Given this list of marker genes TFAP2B, GTSF1, IZUMO1, MAPK10, MST1R, PTCRA, OPN1SW, TRIM33, KCND2, KCNIP4, ZNF358, SLN, HVCN1, LEFTY2, KLHL23, DYRK1B, PLAG1, TWSG1, KCNJ2, RIN1, KRT76, FGF16, ARHGAP44, KISS1R, HOXC13, MIR124-1HG, TMEM269, WT1, KAZN, CRYBA2 (NCBI Gene Id 1412), ATP1A4, MARVELD2, SLC6A18, AMHR2, APLNR, MIOX, TACR3, BCLAF3, SOST, MYOD1, KRTAP3-3, DLK1, ZNF25, ENTPD8, NHLRC1, KCNJ14, ERBB2, TMTC4 (transmembrane O-mannosyltransferase targeting cadherins 4), TENT5B, IZUMO1R, MAL, TSPAN9, COL8A2, LCK, C1QL3, FSHB, LCN2, P2RY6, LRRC31, PINK1, MYRIP, LGI4, ENOX1, SLC22A12, TEC (tec protein tyrosine kinase), GJC3, NNMT, KLHL1, TTR, RAB42, IFITM5, EFCAB3, OCIAD2, GATA2, INHBB, GRIA4, IL10, CCDC169, FABP3, GPR27, CPN2, GCOM1, GPR20, COL24A1, SORBS3, OSR2, RAMP2, CORO6, JAG2, DLC1, CD209, DHX29, HCRTR2, SLC5A10, VTI1A, DPPA5, HNF1A, TSKU, PRSS54, PAK6, TRAM1L1, ARHGEF9, WDR45B (WD repeat domain 45B), PDE6B, SEMA5B, SH3D19, ALDH1A3, DUSP8, DISP3, KIF14, TPBG, GJD4, PLAC9, FAM221A, MAP7, GPAT3, CYYR1, CDKN1A (NCBI Gene Id 1026), SH2D2A, STXBP6, CCDC24, ITSN2, GPR135, ACTRT3 (actin related protein T3), FUNDC2, FAM110A, CA12, FAM163B, FOXS1, ATP6V0D2, KRT31, ATP11C, ZNF236, MSH3, OTOA, SLC12A5, CA9 (NCBI Gene Id 768), KRT6A, LRFN3, PPP1R1B, GPR26, VSX2 (visual system homeobox 2), NKAIN1, DHX16, SCRN2, HDHD2, CUX2, CASQ1, PSAPL1, FABP12, ANP32A, B3GALNT1, METTL27, GUCY1A1, CFAP69, ADRA2A, ZCCHC14, COL10A1, CD4, MFGE8, DLG5, ABRACL, VWC2L, MYO1E (myosin IE), PPP1R3A, C12orf42, MITF, JARID2, FGD1, PHOSPHO1, KCTD7, BTC, LRRC4, DCSTAMP, SYT13, MOK, GP1BA (glycoprotein Ib platelet subunit alpha), ADD2, CNTNAP4, KAZALD1, C12orf50, CBX8, CPLANE2, TBR1, CDKN2D, UBL3, FRAT2, RHBDL3, SPAG9, MPP2, S1PR5, UBL4B, PPP2R2B (protein phosphatase 2 regulatory subunit Bbeta), RAPGEF6, MIER1 (MIER1 transcriptional regulator), EPHX1, BVES, RIBC1, USP12, here is a description of the gene set: Genes down-regulated in T conv cells treated with IL35 versus resting T reg cells. Human Gene Set: GSE24210_IL35_TREATED_VS_RESTING_TREG_DN species: Homo sapiens from publication Collison LW, Chaturvedi V, Henderson AL, Giacomin PR, Guy C, Bankoti J, Finkelstein D, Forbes K, Workman CJ, Brown SA, Rehg JE, Jones ML, Ni HT, Artis D, Turk MJ, Vignali DA (PMID 20953201) Regulatory T cells (Tregs) play a critical role in the maintenance of immunological self-tolerance. Naïve human or murine T cell treatment with the inhibitory cytokine IL35 induces a regulatory population, termed iTR35, that mediates suppression via IL35, but not IL10 or TGFβ, neither express nor require Foxp3, are strongly suppressive in five in vivo models, and exhibit in vivo stability. Treg-mediated suppression induces iTR35 generation in an IL35- and IL10-dependent manner in vitro, and in inflammatory conditions in vivo in Trichuris-infected intestines and within the tumor microenvironment, where they appear to contribute to the regulatory milieu. iTR35 may constitute a key mediator of infectious tolerance and may contribute to Treg-mediated tumor progression, and ex vivo-generated iTR35 may possess therapeutic utility.